Given this list of marker genes Tpcn2, Pikfyve, AU040320, Cav1, Rnasek, Eps15, Cav2, Siglec1, here is a description of the gene set: studied in species Mus musculus Mouse Gene Set: GOBP_RECEPTOR_MEDIATED_ENDOCYTOSIS_OF_VIRUS_BY_HOST_CELL Any receptor-mediated endocytosis that is involved in the uptake of a virus into a host cell; successive instances of virus endocytosis result in the accumulation of virus particles within the cell.